Given this list of marker genes SNRPN, VCP, NLGN3, MAPT, MECP2, SPTBN1, NLGN4X, PSEN1, TREM2, SQSTM1, NTNG1, GABBR2, GRN, SMC1A, CDKL5, CHMP2B, TMEM106B, here is a description of the gene set: Behavior characterized by an abnormal limitation to a few interests and activities. Human Gene Set: HP_RESTRICTIVE_BEHAVIOR Restrictive behavior species: Homo sapiens